Given this list of marker genes FGF22, FGF14, FGF3, FGF19, FGF7, FGF2, FRS3, FGF20, NRXN1, FGF18 (fibroblast growth factor 18), FGF8, FGF12, FGF4, FGF5, FGF23, KL, FGF10, FLRT3, FLRT2, FGF1, FGF9, FGF16, FLRT1, FGF6, NPTN, KLB, FGF17, FRS2, FGF21 (fibroblast growth factor 21), here is a description of the gene set: Binding to a fibroblast growth factor receptor (FGFR). studied in species Homo sapiens Human Gene Set: GOMF_FIBROBLAST_GROWTH_FACTOR_RECEPTOR_BINDING